Given this list of marker genes Prkar1b, Gng8, Ikbkb, Calm1, Yap1, Prkar2b (protein kinase, cAMP dependent regulatory, type II beta), Gng11, Ptpn1, Gnb2, Itga5, Gnb5, Adm, Gng3, P2ry2, Anxa2, Gng5, Gnb3, Gng4, Nfkb1, Gng7, Nfkbia, Prkacb (protein kinase, cAMP dependent, catalytic, beta), Gngt1, Rela, Ppp2r1b, Pdpk1, Ppp2r2a, Gngt2, Rictor, Capns2, Gng10, Prkaca, Ptk2, here is a description of the gene set: Reactome Pathway: Response of endothelial cells to shear stress species: Mus musculus electronically inferred by orthology from the curated human pathway This event has been computationally inferred from an event that has been demonstrated in another species.<p>The inference is based on the homology mapping from PANTHER. Briefly, reactions for which all involved PhysicalEntities (in input, output and catalyst) have a mapped orthologue/paralogue (for complexes at least 75% of components must have a mapping) are inferred to the other species. part of: Cellular responses to mechanical stimuli